Given this list of marker genes GPI, DCTPP1 (dCTP pyrophosphatase 1), APEX1, GPAM, GAS5, MCM6, DUT, SLC16A1, RPL12, CPSF3 (NCBI Gene Id 51692), MRPS18B, RPL22, POLD1, METTL26, HNRNPH2, BABAM1, EEF2, CDK1, RPSA, WDR74, C1QBP, AHCY, SRM, FBL, NPM1, E2F8, RPL10A, DTD1, RARS1, EEF1G, RPL5, RPL18, GGA2, CAD, PPA1, ASS1, MYBBP1A, LONP1, IPO5, UQCRC1 (NCBI Gene Id 7384), SLC5A6, HSPA9, RAD23B, RPL13 (ribosomal protein L13), NME2, EIF1AY, here is a description of the gene set: from publication Iritani BM, Delrow J, Grandori C, Gomez I, Klacking M, Carlos LS, Eisenman RN (PMID 12234922) species: Mus musculus Genes down-regulated by overexpression of MAD1 in primary thymocytes from RAG2 knockout mice. Activated lymphocytes must increase in size and duplicate their contents (cell growth) before they can divide. The molecular events that control cell growth in proliferating lymphocytes and other metazoan cells are still unclear. Here, we utilized transgenesis to provide evidence suggesting that the basic helix-loop- helix-zipper (bHLHZ) transcriptional repressor Mad1, considered to be an antagonist of Myc function, inhibits lymphocyte expansion, maturation and growth following pre-T-cell receptor (pre-TCR) and TCR stimulation. Furthermore, we utilized cDNA microarray technology to determine that, of the genes repressed by Mad1, the majority (77%) are involved in cell growth, which correlates with a decrease in size of Mad1 transgenic thymocytes. Over 80% of the genes repressed by Mad1 have previously been found to be induced by Myc. These results suggest that a balance between Myc and Mad levels may normally modulate lymphocyte proliferation and development in part by controlling expression of growth-regulating genes. Human Gene Set: IRITANI_MAD1_TARGETS_DN